The following is a description of a gene set: studied in species Homo sapiens Genes predicted to be targets of miRBase v22 microRNA hsa-miR-3199 in miRDB v6.0 with MirTarget v4 prediction scores > 80 (high confidence targets). Human Gene Set: MIR3199 from publication Chen Y, Wang X (PMID 31504780), and this is the list of marker genes: INTS9, CDK16, CD28, PRDM6, LRP8, ADCY9, C5orf22, SARM1, ARHGEF7, CLSTN1, POLQ, PDCD10, SULT1C2, SLC6A17, LIN52, GNB1 (NCBI Gene Id 87729), SYNPO2L, EPN2, RFX3, TMEM200A, ZNF251, LVRN, CCDC187, NAP1L1, MTMR11, KDM6B, WTAP, FAM234B, NPAS3, FBXO25, SATB2, DCDC1, DBNDD1, EIF2B1, GP1BA, MAP3K13, CTBP2, CRAMP1, GAB2, MAU2, FAM171A1, CNTFR, B3GALT1, ADAM33, TNPO1